The following is a description of a gene set: Human Gene Set: GOCC_POSTSYNAPTIC_SPECIALIZATION_MEMBRANE The membrane component of the postsynaptic specialization. This is the region of the postsynaptic membrane in which the population of neurotransmitter receptors involved in synaptic transmission are concentrated. species: Homo sapiens, and this is the list of marker genes: LRRC4, CHRNB1 (cholinergic receptor nicotinic beta 1 subunit), CHRNB4, GRM1, PRRT1, ERBB4 (NCBI Gene Id 2066), GABRA5, DLG2, GPR158, GRIN1, GRIK4, CHRNA1, CSMD2, GRIA3 (glutamate ionotropic receptor AMPA type subunit 3), KCND2, LRP8, SORCS2, GRIN3B, ASIC1, KCNH1, ACTN2, LRFN2, SEMA4C, GRIN2D, GRIA1, P2RX6 (purinergic receptor P2X 6), CACNA1C, GABRB2, PTPRO, ABHD17B, GRIK3, RYK, KCNK2, GRIN2A (glutamate ionotropic receptor NMDA type subunit 2A), GRIK2, GRID1, CACNG8, GRIK1, EFNB2, RAPSN, ADCY1, NOTCH1, GABRA2, CNKSR2, SYNDIG1, CACNG5, EPHA7, LRFN4, TMEM108, GSG1L, MKLN1, GABRA3, TRAPPC4, DLG3, PRRT2, LRRTM2, KCNB1, NECTIN3, ELFN2, GRID2, NLGN1, TMEM240, VANGL2, SLC16A7, GABRA4, SHISA6, SHISA9, LRFN3, CRHR1, DAGLA, LRFN1, GLRA2, NLGN4X, GABRG2, FGF22, SLC30A1, ABHD17C, NETO2, DLG1, IGSF9, LIN7B, CACNG4, CHRNA10, GRIA2, GRIK5, PLPPR4, NEO1, DLG4, GABRB1, GABRB3, SEMA4B (semaphorin 4B), SLC12A5, ADGRB3, ELFN1, RGS7BP, GRIN3A, CACNG3, SLITRK5 (NCBI Gene Id 26050), CDH10, NETO1, ADAM22, PRR7, CLSTN2, ABHD17A, SLITRK1, NSG2, OPRD1, GABRA1, SEMA4F, NRCAM, IGSF21, LRRC4B, SCRIB, AKAP9, GRIN2B, SHISA7, CHRND, NLGN2, ASIC2, CHRNA9, CHRM1 (cholinergic receptor muscarinic 1), HTR5A, SIGMAR1, SORCS3, GRIN2C, LIN7C, KCND3, SLITRK3, ANP32E, PTPRS, CACNG7, RGS9, ADRA2A, LRFN5, GRIA4, LIN7A, LRRC4C (NCBI Gene Id 57689), DCC, STX1A, ITGA8, RNF10, LRRTM3, ATP2B2, GABRA6 (NCBI Gene Id 2559), GRM5, CLSTN3, CACNG2, NLGN4Y, EPHA4, LRRTM1